The following is a description of a gene set: PPAR-alpha pathway studied in species Homo sapiens Human Gene Set: WP_PPARALPHA_PATHWAY, and this is the list of marker genes: DBI, CCND1, PPARA, CYP4A11, SLC27A1, NR1H3, ACADM, PLTP, KLK15, CDK1, APOA5, APOA2, CPT2, CDK4, EHHADH, CYP8B1, CYP7A1, APOA1, CPT1A, FABP1, SCP2, RXRA, MYC, ACAA1, UGT1A9, APOC3